Given this list of marker genes SETBP1, SIX1, COCH, MT-TS2, USH1C, FOXP2, CDH23, COL4A6, SIX5, HAAO, SRCAP, MYO7A, FOXI1, USH1G, KCNJ10, PI4KB, EBF3, NDP, TRRAP, ORC1, SLC26A4, ESPN, POU3F4, CLRN1, DDX11 (DEAD/H-box helicase 11), EYA1, HARS1, GREB1L, NEUROG1, TIMM8A, CEP78, PEX6, PCDH15, CIB2, ARSG, here is a description of the gene set: Abnormal cochlea morphology species: Homo sapiens An abnormality of the cochlea. Human Gene Set: HP_ABNORMAL_COCHLEA_MORPHOLOGY